The following is a description of a gene set: species: Mus musculus Any process that stops, prevents, or reduces the frequency, rate or extent of the directed movement of a motile cell or organism in response to a specific chemical concentration gradient. Mouse Gene Set: GOBP_NEGATIVE_REGULATION_OF_CHEMOTAXIS, and this is the list of marker genes: Stap1, Thbs1, Padi2, Nbl1, Ryk, Sema5a, Ptpn2, Cxcl13, Hrg, Cyp19a1, Wnt5a, Grem1, C5ar2, Tnfaip6, Robo1, Dusp1, Sema3f, Rin3, Notch1, Wnt3, Angpt2, Hdac6, Klrk1, Plxna3, Sema3a, Dpp4, Gstp1, Slit1, Slamf8, Robo2 (NCBI Gene Id 72126), Gstp2, Coro1b, Slit2, St6gal1, Mmp28, Gpr18, Aif1, Hc, Nrp1, Dusp3, Mif, Ccl12, Ccn3, Ptgr1, Wnt3a